Given this list of marker genes Nme4, Nme6 (NCBI Gene Id 56803), Nme7, Nme2, Entpd7, Nme3, Nme1 (NME/NM23 nucleoside diphosphate kinase 1), Cad (NCBI Gene Id 69719), Nme5, Ak3, here is a description of the gene set: Mouse Gene Set: GOBP_UTP_METABOLIC_PROCESS The chemical reactions and pathways involving UTP, uridine (5'-)triphosphate. studied in species Mus musculus